Given this list of marker genes LOXL3, TNFSF18, IFNG, IL2, HLA-DRA, FOXP3, HLA-DRB1, RARA, SASH3, GATA3, ZC3H12A, SMAD7, IL23R, NFKBID, CD69, IRF4, CCL19, EP300, BRD2, IL2RG, BRD4, IL27, MALT1, SHB, KCNK18, RC3H1, TNFSF4, PRKCZ, CD83, GPR65, IL12B, IL4R, IL18, ASCL2, LGALS1, KLHL25, RC3H2, SOCS5, BATF, CBFB, NLRP3, OPA1, IL23A, ANXA1, SOCS1, BCL6, TBX21, CD86, CD80, SH3RF1, ZBTB7B, STAT5A, HLX, RUNX1, NFKBIZ, NCKAP1L, JAK3, RUNX3, IL12RB1, HMGB1, MIR21, RIPK2, LGALS9, JUNB, here is a description of the gene set: Human Gene Set: GOBP_REGULATION_OF_CD4_POSITIVE_ALPHA_BETA_T_CELL_DIFFERENTIATION Any process that modulates the frequency, rate, or extent of CD4-positive, alpha-beta T cell differentiation. studied in species Homo sapiens